The following is a description of a gene set: studied in species Mus musculus part of: Signaling by ERBB2 Reactome Pathway: Downregulation of ERBB2 signaling This event has been computationally inferred from an event that has been demonstrated in another species.<p>The inference is based on the homology mapping from PANTHER. Briefly, reactions for which all involved PhysicalEntities (in input, output and catalyst) have a mapped orthologue/paralogue (for complexes at least 75% of components must have a mapping) are inferred to the other species. electronically inferred by orthology from the curated human pathway, and this is the list of marker genes: Rps27a, Nrg3, Ubb, Cdc37, Erbb2, Ptpn18, Egfr, Ptpn12, Matk, Btc, Erbb4 (NCBI Gene Id 13869)